The following is a description of a gene set: Human Gene Set: CUI_DEVELOPING_HEART_RIGHT_ATRIAL_CARDIOMYOCYTE studied in species Homo sapiens from publication Cui Y, Zheng Y, Liu X, Yan L, Fan X, Yong J, Hu Y, Dong J, Li Q, Wu X, Gao S, Li J, Wen L, Qiao J, Tang F (PMID 30759401), and this is the list of marker genes: RNF187, DUSP2, GHRH, MYPN, INPP1, LINC01170 (NCBI Gene Id 103724389), CALB2, NES, CAV1, MTMR9, RASSF8, DPP9, GNAL, CDKN1A, NR4A1, ACTA1, PNP, NR4A2, HAMP, ABRA, MYLK3, CITED4, TAF10, UCP2, SLC30A3, HHIP-AS1 (NCBI Gene Id 648915), COL9A1, NMRK2, HCN4, POFUT2, PAM, BMAL2, DAGLB, EFNB1, KLK6, ULK4, RTN4R, DES (desmin), PEDS1, SPRYD3, LRAT